The following is a description of a gene set: studied in species Mus musculus The chemical reactions and pathways resulting in the breakdown of monosaccharides, polyhydric alcohols containing either an aldehyde or a keto group and between three to ten or more carbon atoms. Mouse Gene Set: GOBP_MONOSACCHARIDE_CATABOLIC_PROCESS, and this is the list of marker genes: Glb1 (galactosidase, beta 1), Hk2, Galt, Tigar, Galm, Gapdh, Tpi1, Tkfc, Bcl2l13 (BCL2 like 13), Eno3, Pfkl, Glb1l3, Lrp5, Ldha, Pfkm, Actn3 (NCBI Gene Id 11474), Eno1, Eno1b, Foxk1, Gm1110, Adcy10, Gale, Eno2, Hk1, Nudt5, Aldh1a1, Bad, Gpi1, Pkm, Trp53, Pfkfb2, Pgm1, Glb1l2, Dhdh, Aldob, Aldoa (NCBI Gene Id 11674), Gck, Rbks, Foxk2, Glb1l, Slc25a12, Glyctk, Galk1, Pgam2, Khk, Mpi, Src, Aldh1a7, Pfkp, Pgk1 (phosphoglycerate kinase 1)